The following is a description of a gene set: Mouse Gene Set: GOMF_SUPEROXIDE_GENERATING_NADPH_OXIDASE_ACTIVITY Catalysis of the reaction: NADPH + 2 O2 = H+ + NADP+ + 2 superoxide. species: Mus musculus, and this is the list of marker genes: Sh3pxd2a, Nox4, Nox1, Pdgfb, Ncf1 (neutrophil cytosolic factor 1, NCBI Gene Id 17969), Nox3, Ncf4, Noxa1, Noxo1, Sh3pxd2b, Cybb, Ncf2